The following is a description of a gene set: Reactome Pathway: WNT ligand biogenesis and trafficking This event has been computationally inferred from an event that has been demonstrated in another species.<p>The inference is based on the homology mapping from PANTHER. Briefly, reactions for which all involved PhysicalEntities (in input, output and catalyst) have a mapped orthologue/paralogue (for complexes at least 75% of components must have a mapping) are inferred to the other species. studied in species Mus musculus part of: Signaling by WNT electronically inferred by orthology from the curated human pathway, and this is the list of marker genes: Wnt3a, Wnt1, Wnt7b, Wnt8b, Vps26a, Wnt9a, Wnt4, Wnt8a, Vps35, Wnt11, Wnt10a, Wnt2b, Wnt7a, Snx3, Wnt16, Wnt3, Wnt10b, Wnt5b, Wnt9b